The following is a description of a gene set: Sharply demarcated, typically linear and approximately horizontal, indentations in the outer surface of the ear lobe. species: Homo sapiens Human Gene Set: HP_ANTERIOR_CREASES_OF_EARLOBE Anterior creases of earlobe, and this is the list of marker genes: TBX1, GPC3, BRAF, PRR12, RERE, GPC4